Given this list of marker genes MAGED2, ARPC2 (actin related protein 2/3 complex subunit 2), KTN1, IGFBP4, TPM4, ARHGAP29, TMSB4X, ITGB1, COL4A1, MYL12A, ETS1, ROCK2, NIN, MSN, HMGB1P5 (high mobility group box 1 pseudogene 5), COL4A2, MYL6 (myosin light chain 6), FN1, HLA-B, APP, CD74, KDR, PIEZO2, PTTG1IP, PLPP3, TUBA1B, LPP (NCBI Gene Id 4026), THY1, CAVIN1, IL6ST, GNAI2, TM4SF1, CLDN5, IER2, NOTCH4, MKI67, ACTR2, CAVIN2, PXDN, MARCKS, MAP4K4, HLA-A, IFITM3, TGFBR2, MEF2C, TIMP3, ESAM, B2M, GMFG, SERPINH1, CD81, EMCN, S100A6, RRBP1, RAMP2, CDC37, CRIP2, A2M, GNG11, ADGRL4, HLA-E, RNASE1, NRP1, EFNB2, ADGRF5, H19, LGALS1, CCND1, FKBP1A, FLT1, UACA, TCF4, RHOA, EGFL7, IGFBP5, LIFR, VAMP5, TMSB10, HSPG2, NES, TPM3, COTL1, RDX, NEAT1, PBX1 (PBX homeobox 1), IFITM2, TM4SF18, EHD3, TCIM, APLNR, PECAM1, MEIS2, NOSTRIN, CD34, ANXA2, PRCP, CALM1, PCDH17, SPARC, SPTBN1, IFI16, KIF5B (kinesin family member 5B), here is a description of the gene set: studied in species Homo sapiens from publication Menon R, Otto EA, Kokoruda A, Zhou J, Zhang Z, Yoon E, Chen YC, Troyanskaya O, Spence JR, Kretzler M, Cebrián C (PMID 30166318) Human Gene Set: MENON_FETAL_KIDNEY_9_ENDOTHELIAL_CELLS